Given this list of marker genes RAB27B, ADIRF, ALCAM, MLPH, TOX3, CYP4B1, CRIP1, ZNF91, IKBKB, GOLGA2P5, INPP5J, DNAJC12, CXXC4, SIDT1, TTC9, PGRMC2, TJP3, TBC1D9, CHST8, COL4A5 (collagen type IV alpha 5 chain), VAV3, MAP9, ST6GALNAC2, GPC1-AS1, ZNF446, SLC9A1, SPDEF (SAM pointed domain containing ETS transcription factor), JMJD7-PLA2G4B, DACH1, CELSR1, MAPT, QDPR, PSD3, ERBB3, GSTM3, NRIP1, CLCN3, ARMT1 (NCBI Gene Id 79624), ASAH1, GUSBP3, GATA3, KDM4B, SLC19A2, ITPR1, LIN7A, CYP2D6, ESR1, MCCC2, RET, RBM47, SLC4A8 (solute carrier family 4 member 8, NCBI Gene Id 9498), IL11, NPDC1 (neural proliferation, differentiation and control 1), STK32B, CLGN, TSFM, ASTN2, DNALI1, TFF3, CDS1, SERPINA5, SLC44A4, DEPTOR, AGR2, DCAF10, MAST4, SLC27A2, CA12, MAPKBP1, N4BP2L2, GALNT6, IVD, GREB1, SLC7A8, SELENBP1, EVL, CCNO, ERBB4, ELAPOR1, C4A, BIK, GATB, IL6ST, here is a description of the gene set: species: Homo sapiens We explored whether the five previously reported molecular subtypes in breast cancer show a preference for organ-specific relapse and searched for molecular pathways involved. The intrinsic gene list describing the subtypes was used to classify 344 primary breast tumors of lymph node-negative patients. Fisher exact tests were used to determine the association between a tumor subtype and a particular site of distant relapse in these patients who only received local treatment. Modulated genes and pathways were identified in the various groups using Significance Analysis of Microarrays and Global Testing. Bone relapse patients were most abundant in the luminal subtypes but were found less than expected in the basal subtype. The reverse was true for lung and brain relapse patients with the remark that absence of lung relapse was luminal A specific. Finally, a pleura relapse, although rare, was found almost exclusively in both luminal subtypes. Many differentially expressed genes were identified, of which several were in common in a subtype and the site to which the subtype preferentially relapsed. WNT signaling was up-regulated in the basal subtype and in brain-specific relapse, and down-modulated in the luminal B subtype and in bone-specific relapse. Focal adhesion was found up-regulated in the luminal A subtype but down-regulated in lung relapse. The five major molecular subtypes in breast cancer are evidently different with regard to their ability to metastasize to distant organ(s), and share biological features and pathways with their preferred distant metastatic site. Genes down-regulated in brain relapse of breast cancer. from publication Smid M, Wang Y, Zhang Y, Sieuwerts AM, Yu J, Klijn JG, Foekens JA, Martens JW (PMID 18451135) Human Gene Set: SMID_BREAST_CANCER_RELAPSE_IN_BRAIN_DN